Given this list of marker genes PTBP3, ZNF148, COMMD3-BMI1, AIDA, LCTL, GSTCD (glutathione S-transferase C-terminal domain containing), FGFR1OP2, CAPN2, MBNL3, NDFIP2, ME1, UEVLD, SFMBT1, TCF12, CLCN4, LATS1, PDZRN4, DTWD2 (DTW domain containing 2), SECISBP2L, NFAT5, ZNF486, IKBIP, KLF8, KL, MMP16, ARMCX3, PRELID2, SCML2, SF3A1, TMTC1, RHOQ, ATXN7L1, REV3L, STYX (NCBI Gene Id 730432), CHN1, PPP5C, XPNPEP1, ASB3, RFC3, GRID2, DUSP7, ACAT2, SMG1, KPNA4, GCC2 (GRIP and coiled-coil domain containing 2), HNRNPDL, RORA, SCAMP1, FGD4, GPALPP1, CTNNA3, RASSF8, KIF20B, FMNL2, MTMR6, PPEF2, C21orf91, FNIP2, BOD1L1, MEX3D, TMEFF2, NOTCH2, RAB27B, CAMSAP2, TRPC1, ZNF747, URI1, DCDC2, ERC2, CD163, CSNK1D, S1PR1, RMND5A, OGFRL1, CLDN12, KIAA1586, TP53INP1, LSAMP, CEP120, MMD, UBE2A (ubiquitin conjugating enzyme E2 A), PGAM1, MINDY2, LACTB2, RPS6KA5, ANKRD22, COL11A1, DUS4L, AFTPH, C11orf87, ZNG1C, ACBD5, ZNF326 (zinc finger protein 326), PRPF39, ABI3BP, BBS10, JARID2, GLIPR1, LMX1A, GASK1A, MFSD8, CYP3A7, CRACD, PPHLN1, TRA2B, TTC13 (tetratricopeptide repeat domain 13), CHST9, CCDC47, RIC1, HMBOX1, NAT1, GAPVD1, SNX16, UNC80, RHPN2, SIX4, CACNA2D3, TRIM9 (tripartite motif containing 9), PRKG1, NUP50, MBIP, TIFAB, SLCO5A1, FAM135A (NCBI Gene Id 80266), NAV2, ZBTB44, ZBTB20, TMTC3, HIPK1, SLC24A3, EVI2A, LRRC7, LARP4, ZNF792, SMAD5, PPP1R27, SCN3A, PPP1R9A, MTFR1, CBFB, TRAM1, ARRDC4, PCLO, B3GALT5 (NCBI Gene Id 105372805), KRT28, NEDD4L, RGPD8, TXLNG, FAM199X, BTF3L4, MAP9, MECP2, PDCD5, PLEKHH2, GOPC, RGS7BP, ITGB6, RESF1, AK3, GABRA4, PAQR9, ZNF492, SLC30A5, BEND7, C5orf24, C6orf120, TMED7, CSGALNACT2 (chondroitin sulfate N-acetylgalactosaminyltransferase 2), TMEM167B, APPBP2 (NCBI Gene Id 10513), PREX2, ZBTB41, ETF1, SPAG9, ACVR2B, FAM133A, DAAM1, PAPOLG, MZT1, TBCA, LACTB, CBX3, IKZF2, METTL8, SEC24A, GULP1, MCF2L2, GATM, MIGA1, DIAPH3, RFX7, PSMC2, UBA6 (NCBI Gene Id 55236), MAML1, ZBTB10, CMPK2, SERINC5, U2SURP, GUCY1A2, MARCHF6, DIP2B, DYNC1I2, FSBP, RO60, MMUT, IGF2BP3, PITX2, ZEB2, MFN1, CRIPT, CIAO2A, HOXD13, TMEM65, ZNF680, ARL6IP6, WAPL, ATXN2, HOMER1 (homer scaffold protein 1), NDC1, ZBTB11, RICTOR, MYCN, PCDH11Y, ANKRD10, HTR2C, RETREG1, DPY19L3, KLF7, BRWD1, NUP160, SCN8A, ANGEL2, GRM5, TNFRSF21, C9orf40, A1CF, HECA (hdc homolog, cell cycle regulator), CFL2, SRP9, ZCCHC8, BCL2L2, ADGRB3, FBXL3, POLR2H, CCDC117, PAX5, SCARF1, MAST4, CACUL1, LRRTM3, KCNJ3, ADH5, PLEKHG1, ZDHHC21, BBX, DEFA6, TMEM200A, RGPD5, FLRT3, MAGT1, THSD7A, MAST3, ANKRD26, UGDH, FZD3, GPC6, NAA30, GABPB1, TFDP3, PPARG, PRRC1, STXBP5, SYTL5 (synaptotagmin like 5), ADAM30, MIDEAS, LCOR, PRKAG2, DHRS1, LVRN, TMEM255A, OAZ1, NOTUM, ZNF608, SDC2, SLU7, ACADL (acyl-CoA dehydrogenase long chain), TOLLIP, PRPF40A, SRSF6, SLC4A7, ZNF454, CHRNA7 (NCBI Gene Id 1139), ACTN4, NUP54, GOLGA6L2, GPR155, SUMF1, ZC3HAV1L, MIER3, WDR47, SFT2D1, ZNF559, GPATCH11, PTGFRN, CARF, CCSER1, CA8, PRKAA2, CCNG2, GRIP1, SKIDA1, CFAP44, NTF3, PROSER1, RNF149, RNF138, ARL13B, NUMB, AGTR1, PTPRR, ZRANB2, CFDP1, FNDC3B, TMEM135, TRUB1, LANCL1, AHSA2P, GTF3C3, ACBD3, WDR26, ZNG1B, CDK6, NRXN1, NOS2, ZNF503, YIPF5, DOLPP1, PPP1R2, ZNG1E, RGPD6, ZNG1F, DYNC1LI2, ADAMTS1, NRG4, SLAIN1, ZDHHC2, GNAQ, BTG3, PCDH11X, PRP4K, ADAM22, FYB2, PDE4D, FGL2, FOXG1, BTG2 (BTG anti-proliferation factor 2), ELL2, EEA1, HDAC9, SYNM, UGT8, CAMLG, SREK1, ZFAND5 (NCBI Gene Id 7763), MED6, AFDN, SENP1, NEGR1, METTL6, CCP110, SH3D19 (NCBI Gene Id 152503), SOX5, ATP11A, SNX30, TTC19, WDR7, KLF10, RAP2A, CYBRD1, CCNY (NCBI Gene Id 219771), HLTF, TBCK, ARID2, ABCA5, BMI1, GUCY1B1, SDE2, CISD2, ANKRD46, SPATA6L, FAM221A, IGF1, MDFIC, CCDC50, PTPRG, SMAD9, SERINC3, NR2C1, RBBP8 (NCBI Gene Id 5932), AP1AR, AQP3, SDF4, LIN7A, FEM1C, CD99, MIER1, SPOCK3, DNAJB4, GRM7, SACS, MAP4K4, TFAM, RGPD4, SAMD8, RC3H1, RALA, ARK2N, EPB41L5, EDIL3, GPR85, SESTD1, RNF217, ZNG1A (NCBI Gene Id 57397), GSE1, SSR3, KLRD1, MBNL2, SPDYE1 (speedy/RINGO cell cycle regulator family member E1), STEAP2, MGARP, TRPC5, EXOC5, FZD7, ZNF652, ARFRP1, MTF1 (metal regulatory transcription factor 1), CLVS2, MEIS2, NCKAP1, RIMOC1, SCN1A, FIGN, ITGAV, RAB8B, LRP1B, DDIT4, SNAP91, IGSF3, RRAGD, LPP, PGRMC2, EPHA3, TRIM2, C3orf38, NFKB1, SRSF3, CEP350, PDE1C, TPM3, CCDC179, MTA1 (metastasis associated 1), LRRC4B, DENND1B, CNTN1, TLCD4 (NCBI Gene Id 148534), EIF2AK2, FRMD5, ZDHHC15, PRKAA1, ALG11 (NCBI Gene Id 440138), FZD5, ADAMDEC1 (NCBI Gene Id 27299), PROK2, GPD2, GABPA, HOOK3, DNAJB14, ODAPH, CCNB1, GCNT1, SEC22C, CERS6, SAMTOR, ANAPC1, LMCD1, BNIP3, PHYHIPL, ZBTB25, SANBR, SETD2, RAP1A, UTP3, KATNBL1, BRWD3, here is a description of the gene set: Genes predicted to be targets of miRBase v22 microRNA hsa-miR-548ap-5p, hsa-miR-548j-5p in miRDB v6.0 with MirTarget v4 prediction scores > 80 (high confidence targets). studied in species Homo sapiens Human Gene Set: MIR548AP_5P_MIR548J_5P from publication Chen Y, Wang X (PMID 31504780)